The following is a description of a gene set: species: Homo sapiens Neighborhood of TERF1 telomeric repeat binding factor (NIMA-interacting) 1 in the MORF expression compendium Human Gene Set: MORF_TERF1 Neighborhood of TERF1, and this is the list of marker genes: HNRNPD, PUM2, FUS, XPO7, RBM6, PRPF8, POLR2A, LRPPRC (NCBI Gene Id 10303), KRIT1, ARIH2, DDX49, ATXN2L, NONO, BRD8, TIAL1, ILF2, STARD7, TERF1 (NCBI Gene Id 7013), SERP1, PABPN1, TAX1BP1, STK24, ANAPC5, GNB1, SMNDC1, NAP1L4, POLR2C, XPO1, DHX38, CAPZA1, PTP4A2, TCEA1, EIF1AX, YWHAQ, HNRNPU, HNRNPUL1, KXD1, CS, PUM1, RNF44, FOXJ3, ACP1, EPRS1, SUMO2, EIF4A2, GPAA1, POM121, SMARCC2, SEPTIN7, PDXDC2P-NPIPB14P, ARFGEF1, GAK, SAFB, HNRNPR, ARFGAP2, RAD23A, RNPS1, XRCC5, SNRNP200, SDR39U1, HNRNPK, CTDNEP1, SRRM1, KHDRBS1, DDX39B, DNAJC8, U2AF1